Given this list of marker genes NRG1, ACTC1, RBPJ, ENG, DLL4, TGFB1, COL11A1, TNNI3, BMP10, NKX2-5, NOTCH1, XIRP2, FGFR2, FOXH1, BMP2, NAGLU, TNNC1, WNT2, TGFBR1, RYR2, MYLK2, BMPR1A, DSP, ANKRD1, NOG, MYBPC3, MIR195, MYH7, TNNI1, EDNRA, S1PR1, UBE4B, ZFPM2, MYL2, PTCD2, PROX1, EGLN1, TNNT2, HEG1, PKP2, TPM1, MED1, TGFBR3, POU4F1, TGFB2, FOXC1, TCAP, SMAD4, ISL1, MYL3, TBX20 (T-box transcription factor 20), FKBP1A, HAND1, HEY2, FOXC2, LRP2, SMAD7, PITX2, ZFPM1, TTN, CHD7, MYH6, here is a description of the gene set: studied in species Homo sapiens The process in which the anatomical structures of cardiac muscle tissue are generated and organized. Human Gene Set: GOBP_CARDIAC_MUSCLE_TISSUE_MORPHOGENESIS